Given this list of marker genes CALR, CYP26C1, PRAME, CNOT1, CTBP2, EZH2, CYP26A1, TGIF1, CYP26B1, ASXL1, SNW1, TRIM16, AKR1C3, NR2C1 (NCBI Gene Id 7181), KLF2 (KLF transcription factor 2), ZNF536, DHRS3, here is a description of the gene set: Any process that modulates the frequency, rate or extent of retinoic acid receptor signaling pathway activity. Human Gene Set: GOBP_REGULATION_OF_RETINOIC_ACID_RECEPTOR_SIGNALING_PATHWAY species: Homo sapiens